Given this list of marker genes Cyp2a5, Cyp17a1, Cyp2r1, Cyp2c68, Cyp2c23, Cyp2c67, Hmox1, Cyp7b1 (cytochrome P450, family 7, subfamily b, polypeptide 1), Coq6, Cyp2d12, Cyp2t4, Cyp2c39, Cyp2j11, Cyp2s1, Cyp2c50, Cyp2a4, Cyp2j7, Cyp3a41b, Cyp2c29, Cyp1a2, Cyp2a22, Cyp2d9, Cyp7a1, Cyp2c70, Cyp2c54, Cyp2j12, Cyp4f40, Cyp2d10, Cyp2b23, Cyp21a1, Cyp3a59, Cyp2a12, Cyp2j9, Cyp3a44, Cyp3a13, Cyp4a10, Cyp3a41a, Cyp4f13, Cyp8b1, Cyp2c55, Cyp2g1, Cyp1b1, Cyp19a1, Cyp2j13, Cyp2b19, Cyp4a12a, Cyp4f14, Ahr, Cyp3a25, Cyp2b9, Cyp2b13, Cyp2d26, Cyp3a16, Cyp4f18, Cyp2c69, Cyp2c66, Cyp3a11, Cyp4a29, Cyp4a30b, Cyp2w1, Cyp3a57, Cyp4f15, Cyp2b10 (NCBI Gene Id 13091), Cyp2c40, Cyp2d11, Cyp2j8, Cyp4a32, Cyp27a1, Cyp2f2, Hmox2, Cyp4a14, Cyp2d22 (cytochrome P450, family 2, subfamily d, polypeptide 22), Cyp4a31, Cyp2ab1, Cyp2c65, Cyp39a1, Cyp2j6, Cyp1a1, Cyp4v3, Cyp4a12b, Cyp4b1, Cyp2u1, Cyp2c37, Cyp2d40, Cyp2d34, Cyp2c38 (NCBI Gene Id 639008), Cyp2e1, Cyp2j5 (cytochrome P450, family 2, subfamily j, polypeptide 5), here is a description of the gene set: Mouse Gene Set: GOMF_OXIDOREDUCTASE_ACTIVITY_ACTING_ON_PAIRED_DONORS_WITH_INCORPORATION_OR_REDUCTION_OF_MOLECULAR_OXYGEN_REDUCED_FLAVIN_OR_FLAVOPROTEIN_AS_ONE_DONOR_AND_INCORPORATION_OF_ONE_ATOM_OF_OXYGEN Catalysis of an oxidation-reduction (redox) reaction in which hydrogen or electrons are transferred from reduced flavin or flavoprotein and one other donor, and one atom of oxygen is incorporated into one donor. species: Mus musculus